Given this list of marker genes Phb2, Tgfb1, Wnt5a, Irf2bpl, Stat5b, Med1, Stat5a, Ncoa3, Nell2, Areg, here is a description of the gene set: Mouse Gene Set: GOBP_DEVELOPMENT_OF_SECONDARY_FEMALE_SEXUAL_CHARACTERISTICS studied in species Mus musculus The process whose specific outcome is the progression of the secondary female sexual characteristics over time, from their formation to the mature structures. In female humans, these include growth of axillary and pubic hair, breast development and menstrual periods. Their development occurs in response to sex hormone secretion.